The following is a description of a gene set: species: Homo sapiens Genes down-regulated in comparison of dendritic cells (DC) exposed to L. major versus DCs exposed to 50 worms/well B. malayi. Human Gene Set: GSE360_L_MAJOR_VS_B_MALAYI_HIGH_DOSE_DC_DN Monocyte-derived dendritic cells (DC) and macrophages (MΦ) generated in vitro from the same individual blood donors were exposed to five different pathogens, and gene expression profiles were assessed by microarray analysis. Responses to Mycobacterium tuberculosis and to phylogenetically distinct protozoan (Leishmania major, L. donovani, Toxoplasma gondii) and helminth (Brugia malayi) parasites were examined, each of which produces chronic infections in humans yet vary considerably in the nature of the immune responses they trigger. from publication Chaussabel D, Semnani RT, McDowell MA, Sacks D, Sher A, Nutman TB (PMID 12663451), and this is the list of marker genes: SLC7A8, ZNF204P, KIAA0753, KCNA4, ATR, VCL, RNF187, MLLT1, HSPG2, ATP6V1G2, TAT, ACVR1, ATP2B1, TKT, STXBP5L, SLC35A2, RABGAP1, PAIP1, STIM1, REEP5, MPHOSPH10, CORO2A, OGDH, DAPK1, SPOP, JUP, PCNA, PLAAT3, HDLBP, IMP4, OSBPL2, NDUFS6, RAB11FIP2, IPO9, MMP16, CA5A, RTF1, C17orf75 (chromosome 17 open reading frame 75), RBMXL2 (NCBI Gene Id 27288), RHOBTB1, SH3GL1, RYR3, GRPEL1, C6orf47, ZNF230, TEAD3, AGO2, TRRAP, PSME4, UFL1, FRAT2, SRP72, GNG4, DIXDC1, ZZZ3, UROS, GPRC5B, EPHA7, AQP3, BUB1, PGM5, ADORA3, UPF2, PPP2R2B, APLNR, DISC1, FLRT2, PLOD3, TUSC2, EBNA1BP2 (NCBI Gene Id 10969), EIF4E, POLR2E, MRPS12, DUSP7, TNNT3, BCAR3, DLC1, NUP42 (nucleoporin 42), CD37, IP6K1, FGF1, ZNF195, NKRF, CDC42EP4, MSLN, NUP160, SNRPA1, ZNHIT1, RBL1 (NCBI Gene Id 5933), MEOX2, GCNT2, HOXA10, ZNF273, SEMA3E, SCN5A, ROR2, HCG4, ANAPC5, RPP14, RPL22, PLXNB2, OAT, ROCK1, GABPA, HBBP1, CA4, DYNC1H1, TBXAS1, PHB2, BCKDHA, RPL3, AP2A2, PTPN6, CADM4, AFG3L2, MLEC (malectin), TMEM243 (NCBI Gene Id 79161), DDX52, MYO1E, GDF11, CD1E, PSMD4, FPGS, TRA2B, UCK2, MAF, ZNF217, APOH, POLD2, MSL3, STX5, KAT5, ZBED1, RNASE6, SLC23A2, IDH2, PLCB2, MCM3AP, CACNA1C, VRK1, BAHD1, GABARAPL2, SFMBT1, FIBP, KLF4, BRD3, SCAF8, WASHC5, RCBTB2, DNAJC2, TFAP4, RTCA, PPM1F, SLCO2B1, TAX1BP3, AFF1, CD9, PDCD1, OTUD3, DHRS2, NUP210, ASXL1, IFI16, PKD1, KIF14, PRDM1, NAT1, IL1RL1, MYCL, ATP8A1, GPX7, CCNT1, SPTBN2, PQBP1, N4BP2L2-IT2, RUVBL1, RB1, DGKD, MRC2, NPRL3, AJAP1, SYT17, CPVL, JARID2, KDM4B, CTSO, ADORA2B, PMVK, MAN2A1, KHSRP, SEM1 (NCBI Gene Id 7979), MCC, TARBP2, KIF11, SLC16A2, PRKY, DAB2